Given this list of marker genes Fzr1, Birc5, Cebpb, Endov, Prdx1, Plce1, Ptprj, Mtdh, Lypd3, Dnajc27, Mmp19, Cyp1b1, Ptger4, Lonp1 (NCBI Gene Id 74142), Hcst, Mmp11, Cd34, Foxn1, Agtr2, Mapkapk2, Stag1, Brca2, Ralgds, Tnf, Tnik, Loxl2, Dek, Ier3, Trem1, Il12b, Ahrr, Mir21a, Pten, Mpg, Mif, Mgat3, Ptk2, Mmp1a, Mki67, Gata6os, Ptger1, Strap, Ephx1, Tiam1, Ptgs2, Trp53, Fgf22, Foxm1, Uri1, Cd96, Spp1, Tlr4, Kdm4c, Cacfd1, Ptp4a3, Hras, Cyp1a2, Pik3ca, Terc, Il6, Trim27, Fntb, Il6ra, Slc3a2, Neu3, Fxyd5, Myd88, Chd1l, Il1r1, Muc4, Pvr, Pard3, Skil, Cdkn1b, Mir301, Hipk1, Cd151, Arl6ip5, Stat3, Pla2g4a, Camk2g, Klk6, Tert, Retnlb, Cdkn2a, Itgb1, Ptger2, Ccl2, Ar, Tnfaip8l3, Pycard, Cyp2e1, Il23a, here is a description of the gene set: from publication Motenko H, Neuhauser SB, O'Keefe M, Richardson JE (PMID 26092688) Mouse Gene Set: MP_DECREASED_INCIDENCE_OF_TUMORS_BY_CHEMICAL_INDUCTION Mouse genes annotated to decreased incidence of tumors by chemical induction (MP:0004502) retrieved from the Mouse Genome Informatics database via MouseMine studied in species Mus musculus